The following is a description of a gene set: Integrated breast cancer pathway Human Gene Set: WP_INTEGRATED_BREAST_CANCER_PATHWAY species: Homo sapiens, and this is the list of marker genes: PIAS1, TP53, BLM, RAP1A, RASGEF1A, CASP8, APOBEC3G, GDI1, FOSL2, JUN, ALKBH1, CTNNB1, HIPK2, BRAF, MRE11 (NCBI Gene Id 4361), PIK3R2, JAKMIP1, SMAD4, ITPKC (NCBI Gene Id 80271), MIR21, SIRT1, ZMIZ1, CCND1, USP15, MTOR (NCBI Gene Id 2476), EGFR (epidermal growth factor receptor), BMPR2, RB1, PAK1, TAB1, MIR29B2, ODC1, TSC1, CDK2, EDAR, FOXO1, SMAD1, RHO, MAP3K13, TSC2, FOSL1, SELENOK, GRN, CDK7, HDAC1, TPR, RAD51, ESR1, USP38, RAC1, RAD50, MYT1, CDC25B, ZNF655, ATM, NCOA3, TGFBR2, RHEB, CREB1, TFPI, PTEN, LGALS13, CYP19A1, NF1, MYC, SP1, BRCA1, MYCBP2, PPP4R3B, CDK4, ANXA1, SMAD6, AURKA, RPP38, BACH1, CDC25A, MMP1, DHTKD1, STAT1, VEGFA, CHUK (NCBI Gene Id 1147), CDH1, USP16, MAPK1, PHB1 (prohibitin 1), NAB1, CASP3, BARD1, CERK, PPP4R3A, ATF1, JAK1, CHEK1, NFKB1, WEE1, FAU, TRADD, PLK3, AHR, ATR, DCAKD, SMAD7, ZMYND8, BMPR1A, BAK1, ARAF, CSNK1D, MDM2, GSK3A, ERAL1, DAG1, MAX, GADD45A, RASGRP3, TGFBR1, BAX, AKT1, CDC42, PLK1, PKIA, XRCC3, RALGAPA1, MAP3K7CL, RAD54L, SMARCA4, NUP85, FILIP1, NOXA1, UBE2F, IMPA1, FER, FADD (NCBI Gene Id 8772), BID, IRS1, HMGCR, AR, CASP9, MSH6, CCNB1IP1, BAD, MSH2, ABL1, PIGR, SMAD2, RALA, BRCA2, CHEK2, MIR29B1, STK11, PML, RRAS, USP21, E2F1, BCL2, EP300, KRAS